Given this list of marker genes KYNU (NCBI Gene Id 8942), TM4SF1, CXCL3, TGFB1I1, H1-0, CXCL13, INHBA, PCDH9 (NCBI Gene Id 57123), TNFSF10, SVIL, STAT4, CREM, VNN1, NR4A2, TPBG, MAFF (NCBI Gene Id 23764), H2AC18, TNFSF4, OPTN, H2AC6, PTPRC, CXCL6, RBPMS (RNA binding protein, mRNA processing factor), H2BC12, AREG, MPZL2, NEAT1, CYTIP, SOD2, CCL19, TSPAN31, PTGS2, GLIPR1, EVI2A, IL18R1, GUCY1A1, DST, TFPI, CXCL10, TCF7L2, EMP1, GABPB1-IT1, FTH1, IL1B, NFAT5, NRIP1, ALOX5, CXCL11, NIBAN1, GBP2, H2BC21, DDX17, MIR22HG, MLLT3, FNBP1, HLX, CXCL1, ALDH1A1, FXR1, SPTBN1, EBI3, CXCL2, PMCH, CRHBP, PPFIBP1, here is a description of the gene set: from publication Graham SM, Vass JK, Holyoake TL, Graham GJ (PMID 17717066) Human Gene Set: GRAHAM_NORMAL_QUIESCENT_VS_NORMAL_DIVIDING_UP Genes up-regulated in quiescent vs dividing CD34+ cells isolated from peripheral blood of normal donors. studied in species Homo sapiens Quiescent and dividing hemopoietic stem cells (HSC) display marked differences in their ability to move between the peripheral circulation and the bone marrow. Specifically, long-term engraftment potential predominantly resides in the quiescent HSC subfraction, and G-CSF mobilization results in the preferential accumulation of quiescent HSC in the periphery. In contrast, stem cells from chronic myeloid leukemia (CML) patients display a constitutive presence in the circulation. To understand the molecular basis for this, we have used microarray technology to analyze the transcriptional differences between dividing and quiescent, normal, and CML-derived CD34+ cells. Our data show a remarkable transcriptional similarity between normal and CML dividing cells, suggesting that the effects of BCR-ABL on the CD34+ cell transcriptome are more limited than previously thought. In addition, we show that quiescent CML cells are more similar to their dividing counterparts than quiescent normal cells are to theirs. We also show these transcriptional differences to be reflected in the altered proliferative activity of normal and CML CD34+ cells. Of the most interest is that the major class of genes that is more abundant in the quiescent cells compared with the dividing cells encodes members of the chemokine family. We propose a role for chemokines expressed by quiescent HSC in the orchestration of CD34+ cell mobilization. Disclosure of potential conflicts of interest is found at the end of this article.